The following is a description of a gene set: studied in species Mus musculus Any process that results in a change in state or activity of a cell or an organism (in terms of movement, secretion, enzyme production, gene expression, etc.) as a result of a heparin stimulus. Mouse Gene Set: GOBP_RESPONSE_TO_HEPARIN, and this is the list of marker genes: Egr1, Sox9, Ext1, Sfrp1, Gpihbp1, Slit2